Given this list of marker genes Gata2, Bhlha15, Xbp1, Hif1a, Fzd5, Pgr, Gpat4, here is a description of the gene set: species: Mus musculus The developmental process, independent of morphogenetic (shape) change, that is required for a glandular epithelial cell to attain its fully functional state. A glandular epithelial cell is a columnar/cuboidal epithelial cell is a cell found in a two dimensional sheet with a free surface exposed to the lumen of a gland. Mouse Gene Set: GOBP_GLANDULAR_EPITHELIAL_CELL_MATURATION